The following is a description of a gene set: studied in species Mus musculus Mouse Gene Set: GOBP_REGULATION_OF_NEUTROPHIL_MEDIATED_CYTOTOXICITY Any process that modulates the rate, frequency or extent of neutrophil mediated killing of a target cell, the directed killing of a target cell by a neutrophil., and this is the list of marker genes: Cxcl1, Cxcl5, Arg1, Dnase1, Pomc, Dnase1l3, F2rl1